Given this list of marker genes Lfng, Txnl4a, Rpf2 (NCBI Gene Id 67239), Bola1, Osbpl8, Relb, Zfp106, Gnl3, Txnrd2, Lrba, Agpat3, Kdm5a, Fgl2 (NCBI Gene Id 14190), Ppil4, Ndufa3 (NADH:ubiquinone oxidoreductase subunit A3), Plcg2, Mrpl52, Cotl1, Cisd3, Eif2s1, Cd52, Ilk, Tubb4b, Tnfrsf18 (NCBI Gene Id 21936), Tsen34, Pfn1, H13, here is a description of the gene set: studied in species Mus musculus Genes positively differentially expressed in cell type: NK cell upon treatment with cytokine: RANKL in mouse lymph nodes in vivo. Cytokines mediate cell-cell communication in the immune system and represent important therapeutic targets. A myriad of studies have highlighted their central role in immune function, yet we lack a global view of the cellular responses of each immune cell type to each cytokine. To address this gap, the authors created the Immune Dictionary, a compendium of single-cell transcriptomic profiles of more than 17 immune cell types in response to each of 86 cytokines (>1,400 cytokine-cell type combinations) in mouse lymph nodes in vivo. A cytokine-centric view of the dictionary revealed that most cytokines induce highly cell-type-specific responses. For example, the inflammatory cytokine interleukin-1β induces distinct gene programmes in almost every cell type. A cell-type-centric view of the dictionary identified more than 66 cytokine-driven cellular polarization states across immune cell types, including previously uncharacterized states such as an interleukin-18-induced polyfunctional natural killer cell state. Mouse Gene Set: CUI_NK_CELL_RANKL_RESPONSE_UP from publication Cui A, Huang T, Li S, Ma A, Pérez JL, Sander C, Keskin DB, Wu CJ, Fraenkel E, Hacohen N (PMID 38057668)